The following is a description of a gene set: from publication Amit I, Garber M, Chevrier N, Leite AP, Donner Y, Eisenhaure T, Guttman M, Grenier JK, Li W, Zuk O, Schubert LA, Birditt B, Shay T, Goren A, Zhang X, Smith Z, Deering R, McDonald RC, Cabili M, Bernstein BE, Rinn JL, Meissner A, Root DE, Hacohen N, Regev A (PMID 19729616) species: Homo sapiens mouse primary BMDCs were stimulated with tlr ligands and gene expression changes were profiled on Affymetrix arrays Genes down-regulated in comparison of dendritic cells (DC) stimulated with poly(I:C) (TLR3 agonist) at 2 h versus DC cells stimulated with CpG DNA (TLR9 agonist) at 2 h. Human Gene Set: GSE17721_POLYIC_VS_CPG_2H_BMDC_DN, and this is the list of marker genes: PI4K2B, HNRNPLL, ALPK2, TLR6, SH3BP4, RAB8B, NECTIN2, SDC1, CYP4A11, PLA2G2E, TCP11, CD83, SFSWAP, CIMIP2A, MARCKS, RGL1 (ral guanine nucleotide dissociation stimulator like 1), VCAM1, PDE6G (NCBI Gene Id 5148), SELENOK, OTP, SLC25A25, IER5, ALPG, APLP1, SUCO, RAB27A, KRT85, HNF4A (hepatocyte nuclear factor 4 alpha), IGSF9, SMPD4 (sphingomyelin phosphodiesterase 4), TASOR2, PPP2R2A (NCBI Gene Id 5520), UFM1, CST7, AMIGO1 (NCBI Gene Id 57463), PALS1, PRICKLE1 (NCBI Gene Id 144165), FABP4, PHF13, SEC63, HLA-DRB1, MACROD2, SIAH2, MEF2A, ABHD14A (NCBI Gene Id 25864), UBL7, CDKN1B, GDF15, CAPN3, USP53, ZBTB37, WNK1, NCAPH, BCL2L11, ABCB8, FBXL3, PAX5, FPR1, TMEM243, NFE2L2, ATP2B2, RAD51, SLC25A17, MC5R, SLC22A5, PLPPR2, GPR137B (NCBI Gene Id 7107), NUDT9, UBE2O, MDM2, TNFRSF11B, TCF15, PHLDA1, HSP90AA1, MUS81, ST3GAL1, TPTE, GNAQ, SSBP4, TMEM115, ATP10A, FGB, B3GALT2, SPRYD7, EPS8L1, SPARCL1, SPATA13 (spermatogenesis associated 13), KIF21A, SMOX, CALCRL, IGSF6, TYMS, IL36G, HSPH1, ST3GAL5, WDR36, TBK1, P2RY14, RND3, C5orf47, B3GAT1, MAPK8, NLRP3, FKBP11, USP12, MRPS6, AGBL5, NCK2, HILPDA, SPTBN4, NCK1, TGM2, PTGES, TLR1, TTC36, DAPP1, CAMKK2 (NCBI Gene Id 121657), HSD17B12, DNAJB4, CCL13, ADSS2, GMEB1, KCTD10, HAGH, NUP62, DGLUCY, LAD1, TUBB2A, MT2A, HDLBP, GFI1, MAPK6, COL6A1, AKR1E2, SOWAHC (sosondowah ankyrin repeat domain family member C), ARHGAP21, COL15A1, DCBLD2, FAM133B, WLS, CRY1, RIBC2, HCN2, GADD45A, NFKBIB, EIF1AY, ALPK3, BATF, CCL7, CNOT7, MDFIC, IKBKE, SELENOT, C4B, JAG1 (NCBI Gene Id 3715), NDEL1, ATP6V0E2, IL12A, CD82, S1PR3, SIMC1, XPNPEP1, ADHFE1, RCL1, RBM4B, TLR2, TFEC, PLCL2, SRY, SPRED1, SPRY1, POLR1E (NCBI Gene Id 64425), ATP5PF, DUSP2, CDC73, ADM, HSD17B11, FBXO15, CD200, AMN, BRI3, IL1RAP, SERPINE1, STIP1, ANKZF1, GSTM5, SRFBP1, SLC7A11, CD68, LY75, COL6A2, CYTH2, MTF1, PGS1, NR3C1, CKB, RIPPLY3, HERPUD1, CPB1, NCR1